Given this list of marker genes CHRNA7, ASS1, GUCY2C, ALB, PHAX, GSTP1, A4GALT, AZU1, EPHX2, TMEM181, DSG1, here is a description of the gene set: Human Gene Set: GOMF_TOXIC_SUBSTANCE_BINDING studied in species Homo sapiens Binding to a toxic substance, a poisonous substance that causes damage to biological systems.